Given this list of marker genes DOCK10, DOCK11, BCL3, CDH17, DLL1, ADAM10, TAOK3, PTK2B, LFNG, MFNG, NOTCH2, here is a description of the gene set: species: Homo sapiens Human Gene Set: GOBP_MARGINAL_ZONE_B_CELL_DIFFERENTIATION The process in which a B cell in the spleen acquires the specialized features of a marginal zone B cell. Marginal zone B cells are localized in a distinct anatomical region of the spleen that represents the major antigen-filtering and scavenging area (by specialized macrophages resident there). It appears that they are preselected to express a BCR repertoire similar to B-1 B cells, biased toward bacterial cell wall constituents and senescent self-components (such as oxidized LDL).